The following is a description of a gene set: A type of hearing impairment prominently characterized by a difficulty in understanding speech, rather than an inability to hear speech. Poor speech discrimination is a very common symptom of high frequency hearing loss. Human Gene Set: HP_ABNORMAL_SPEECH_DISCRIMINATION Abnormal speech discrimination studied in species Homo sapiens, and this is the list of marker genes: TMEM43, DIAPH3, AIFM1, ATP11A, KPTN